The following is a description of a gene set: Acetabular spurs species: Homo sapiens Human Gene Set: HP_ACETABULAR_SPURS The presence of osteophytes (bone spurs), i.e., of bony projections originating from the acetabulum., and this is the list of marker genes: EVC2, COL2A1, WDR19, EXTL3, DYNC2I1, DYNC2H1, DYNLT2B, EVC